The following is a description of a gene set: Human Gene Set: GOMF_GLYCINE_TRANSMEMBRANE_TRANSPORTER_ACTIVITY Enables the transfer of glycine from one side of a membrane to the other. Glycine is aminoethanoic acid. studied in species Homo sapiens, and this is the list of marker genes: SLC6A9, SLC36A3, SLC6A5, SLC36A1, SLC38A1, SLC36A2, SLC38A5, SLC7A8, SLC25A38, SLC32A1